Given this list of marker genes STEAP3, ZNF420, BID, PRELID1, TP63, CREBBP, PPP1R13B, TP53BP2, TP53INP1, BAX, AIFM2, TP53, PMAIP1, ATM, PRELID3A, TP53AIP1, BNIP3L, BBC3, TRIAP1, TP73, here is a description of the gene set: studied in species Homo sapiens TP53 Regulates Transcription of Genes Involved in Cytochrome C Release Human Gene Set: REACTOME_TP53_REGULATES_TRANSCRIPTION_OF_GENES_INVOLVED_IN_CYTOCHROME_C_RELEASE